Given this list of marker genes Trem2, Stap1, Tlr2, Ptpn2, Csf1, Tlr4, here is a description of the gene set: species: Mus musculus Mouse Gene Set: GOBP_REGULATION_OF_RESPONSE_TO_MACROPHAGE_COLONY_STIMULATING_FACTOR Any process that modulates the frequency, rate or extent of response to macrophage colony-stimulating factor.